Given this list of marker genes Timm17b, Dnajc19, Grpel2, Timm23, Timm17a, Dnajc15, Timm44, Pam16, Timm50, Timm21, Grpel1, Romo1, here is a description of the gene set: The protein transport machinery of the mitochondrial inner membrane that typically transports proteins that possess a matrix-targeting N-terminal presequence. The TIM23 complex contains three essential Tim proteins: Tim17 and Tim23 are thought to build a preprotein translocation channel while Tim44 interacts transiently with the matrix heat-shock protein Hsp70 to form an ATP-driven import motor. species: Mus musculus Mouse Gene Set: GOCC_TIM23_MITOCHONDRIAL_IMPORT_INNER_MEMBRANE_TRANSLOCASE_COMPLEX